Given this list of marker genes GABRG2, GABRB3, JRK, SLC2A1, PRNP, VAMP1, CACNA1H, MAPT, DLAT, PIGT, GABRA1, here is a description of the gene set: Human Gene Set: HP_JERKY_HEAD_MOVEMENTS studied in species Homo sapiens Jerky head movements